The following is a description of a gene set: DNA amplifications and deletions frequently contribute to the development and progression of lung cancer. To identify such novel alterations in small cell lung cancer (SCLC), we performed comparative genomic hybridization on a set of 24 SCLC cell lines, using cDNA microarrays representing approximately 22,000 human genes (providing an average mapping resolution of <70 kb). We identified localized DNA amplifications corresponding to oncogenes known to be amplified in SCLC, including MYC (8q24), MYCN (2p24) and MYCL1 (1p34). Additional highly localized DNA amplifications suggested candidate oncogenes not previously identified as amplified in SCLC, including the antiapoptotic genes TNFRSF4 (1p36), DAD1 (14q11), BCL2L1 (20q11) and BCL2L2 (14q11). Likewise, newly discovered PCR-validated homozygous deletions suggested candidate tumor-suppressor genes, including the proapoptotic genes MAPK10 (4q21) and TNFRSF6 (10q23). To characterize the effect of DNA amplification on gene expression patterns, we performed expression profiling using the same microarray platform. Among our findings, we identified sets of genes whose expression correlated with MYC, MYCN or MYCL1 amplification, with surprisingly little overlap among gene sets. While both MYC and MYCN amplification were associated with increased and decreased expression of known MYC upregulated and downregulated targets, respectively, MYCL1 amplification was associated only with the latter. Our findings support a role of altered apoptotic balance in the pathogenesis of SCLC, and suggest that MYC family genes might affect oncogenesis through distinct sets of targets, in particular implicating the importance of transcriptional repression. Human Gene Set: KIM_MYCN_AMPLIFICATION_TARGETS_DN studied in species Homo sapiens from publication Kim YH, Girard L, Giacomini CP, Wang P, Hernandez-Boussard T, Tibshirani R, Minna JD, Pollack JR (PMID 16116477) Genes negatively correlated with amplifications of MYCN in the SCLC (small cell lung cancer) cell lines., and this is the list of marker genes: DNAJC10, COL1A1, TMEM19, B4GALT4, NDRG1, ATL3, RPS6KC1, CRP, DCN, KRT7, ZDHHC23, EPB41L5, SAYSD1, CEP70, ATP11B, ILDR2, GCA, LINC01278, DZIP3, ZNF738, SLITRK6 (SLIT and NTRK like family member 6), GRB7, LMOD3, BEST3, CFAP70, KLF5, PEG10, YES1, PDCL3, APOBEC3B, NET1, RASA2, USF3, RECQL, WWOX, NKX2-1, RORA, FAM43A, SLC35A5, MORN2, PIK3CD, CCDC191, FAM111A, SLC24A1, MFSD1, ADCY2, ARID4B, KIN, FN1, ASTE1, MYLK, MAGED4, ZNF681, XRN1 (NCBI Gene Id 54464), OPTN, ZNF93, CEP162, ZNF844, TMBIM4, MIR22HG, NME5, PLEKHG1, CFLAR, SLC34A2, KIAA0753, LIPG, PLEKHA5, INSR, TTC39B, ITGB8, PLEKHA2, CAMK1D, TMEM87B, TUSC3, MICAL1, CCNL1, TIMMDC1, WASHC3, GOLGB1, BARD1, INPPL1, HMG20B, TFDP2, PXDN, SULF1, AKAP12, ARID1B, EPAS1, PTPRM, FCGRT, IRX3, LMO7, BMI1, TMEM98, AKTIP, FAM107B, GOLT1B, LINC01963, HSD3B7, ZNF595, MAP3K7, PPP2R3A, CCDC14, CPNE2, CD164, LINC00339, FAHD2A (NCBI Gene Id 90363)